Given this list of marker genes B3GALT2, PEG10, SMAP1, RAP2C, ZNF302, CAAP1, SLC19A4P, MFSD6, ATL2, GDAP2, RIMS2, CREBBP, CALCRL, PLS1, FANCD2, ALPK1, DDX21, SRSF1, HIBADH, CHST10, BMP3, FAM20C, AGBL2, ERC1, RALA, PRG4, CRIPT, NQO1, LRRTM3, RAB28, CYP19A1, ZNF28, SLC10A2 (NCBI Gene Id 6555), ZNF594, NOL7, GEM, CCDC191, TPST2, DNAAF11, OSBPL8, LRRTM2, SAR1B, KBTBD8, ARMCX4, ZNF211, ZNF254, ATP1B4, RIN2, SEC24B, USP38, USP45, WDR11, TRIM44, HAL (histidine ammonia-lyase), CRMP1, CCDC25, ZNF208, DLX5, ZNF91, MEIS2, N4BP2, RHPN2, FUT9, TRHDE, ZSCAN16, SIKE1, PPIC, ZRANB3, DCP1A, ZNF596, ZNF233, ZNF765, FSIP1, ZDHHC2, GRIP1, CDC23, CD1E, SATB1, IL6ST, CPED1, SCN3A, FAM241A, GRIA3, SLC10A7, LCORL, SNAP23, PDE8A, ZNF532, CAPZA2, DIP2B, ZFP90, P2RY10, COL4A1, C5orf63, CCDC71L, TMEM47 (transmembrane protein 47), SYCP2, KANSL1L, RBM17, PIP4P2, DDX24, NAALADL2 (N-acetylated alpha-linked acidic dipeptidase like 2), GIPC2, MSANTD3, ACVR1, TUSC3, CALB1, NRK, GALNT13, PDLIM3, ASCC1 (NCBI Gene Id 51008), ZNF189, SNX19 (sorting nexin 19), GAP43, SLC39A6 (NCBI Gene Id 25800), NTRK2, ZDHHC15, MSL1, RBM15, FBXO47, PRB4, ZNF266, GABRB3, C4orf3, PDPK1, SETD3, PAQR5, BEND7, UBA5, MANEA, ZNF781, USP25, HNRNPD, CSMD2, VAPB, KCNC2, ZCCHC10, TTN, NYAP2, PPP6R3, SERINC1, TRPS1, CTXN2, SLC30A4, TXNDC17, FXR1, EEA1, HRNR, RBM46, PLIN2, KIF21A, FABP7, MAPK8, EIF4G1, NHLRC1, C2CD6 (C2 calcium dependent domain containing 6), ZNF117, GFOD1, ABI1, ZNF426, HNRNPA0, CREBRF, NLGN4Y, here is a description of the gene set: from publication Chen Y, Wang X (PMID 31504780) Genes predicted to be targets of miRBase v22 microRNA hsa-miR-4452 in miRDB v6.0 with MirTarget v4 prediction scores > 80 (high confidence targets). Human Gene Set: MIR4452 studied in species Homo sapiens